Given this list of marker genes PPP2CA, MAP10 (NCBI Gene Id 54627), DYNLT2B, KAT5, WDR62, CTNNB1, UXT, CEP85, CNTRL, KLHL21, CEP89, EML1, TUBG1, CDK5RAP2, MISP, NEK6, POC1B, KNSTRN, RASSF10, PLK2, RASSF1, CETN1, KIF15, DCTN4, LATS2, KLHL22, WDR73, FAM110C, CSAG1, PLK3 (polo like kinase 3), FAM83D, ABRAXAS2, CEP19, AAAS, TOPORS, RAD21, PKP4, CEP104 (centrosomal protein 104), NUBP2, KATNA1, STAG1, GOLGA2, CDC14A, KATNAL2, PPP2CB, RALBP1, NDE1 (nudE neurodevelopment protein 1), CENPF, KASH5, KATNAL1, TUBGCP2, RAB11A, UBXN2B, KIF20B, GPSM2, CALM2, ENKD1, BRCC3, MAPK14, CDC6, GIT1, CUL3, MAD2L1, TNKS, BCCIP, RMDN2, BOD1 (biorientation of chromosomes in cell division 1), CKAP2L, TUBGCP3, DDX11, BNIP2, PLK1, AURKB, CALM1, MAD1L1, KATNB1, RMDN3, CEP250, AURKC, VPS4B, POC1A, DLGAP5, INPPL1, BEX4, HAUS8, TUBGCP5, SPOUT1, CKAP2, HSF1, CDC14B, CTDP1, NEK7, IK (NCBI Gene Id 3550), IKBKG, DYNC1I1, SMC1A, CCNB1, TUBGCP6, CKAP5 (cytoskeleton associated protein 5), TPX2, NEK2 (NIMA related kinase 2), RMDN1, PLK5, TUBGCP4, AURKA, NSMCE1, CEP63, ARHGEF7, NEDD1, ANKRD53, TOPBP1, MAPRE1, TPT1, IRAG2, MAPKBP1, PSRC1, DSN1, NPM1, CDC25B (NCBI Gene Id 994), DYNC1LI1, KIF11, CEP44 (NCBI Gene Id 80817), YPEL5 (NCBI Gene Id 51646), DIAPH3, DNAAF1, HNRNPU, PRC1, TTC28, CEP95, DYNC2I1, PMF1, SMC6, FBF1, KIF2A, OR2A4, UMOD, TACC3, TMEM201, AUNIP, EFHC1, NUP62, VPS4A (vacuolar protein sorting 4 homolog A), KNTC1, CSPP1, NIN, UNC119, FAM161A, ZW10, FAM110A, NUDCD2, KATNBL1, CEP128, CFAP53, EMD, HAUS1, ODF2, BIRC6, DCTN1, ASPM, RGS14, TBCCD1, SGO1, FRY (FRY microtubule binding protein), SBDS, MIS12, NUMA1, SMC3, NSL1, ALMS1, LATS1, STAG2, SPAST, CDC20, RAE1, SPAG5, ALPK1, CALM3, MTCL1, SPDL1, PLEKHG6, CDC14C, NEDD9, here is a description of the gene set: Either of the ends of a spindle, where spindle microtubules are organized; usually contains a microtubule organizing center and accessory molecules, spindle microtubules and astral microtubules. studied in species Homo sapiens Human Gene Set: GOCC_SPINDLE_POLE